The following is a description of a gene set: We identified Pparg as a major orchestrator of the phenotype of adipose-tissue resident regulatory T cells (VAT Tregs). To explore the contribution of Pparg1 and 2 in the generation of the VAT Tregs-specific gene signatures, CD4+FoxP3- T cells were transduced with Foxp3+/- Pparg1 (or Pparg2), treated with Pioglitazone or vehicle, and double sorted for microarray analysis. Genes down-regulated in CD4 over-expressing: FOXP3 and PPARg1 form of PPARG versus FOXP3. Human Gene Set: GSE37533_PPARG1_FOXP3_VS_FOXP3_TRANSDUCED_CD4_TCELL_DN from publication Cipolletta D, Feuerer M, Li A, Kamei N, Lee J, Shoelson SE, Benoist C, Mathis D (PMID 22722857) species: Homo sapiens, and this is the list of marker genes: PSMB10, PHF11 (PHD finger protein 11), GTPBP1, MCUB, IFI27, IRF2, LGALS8, STAT1, PRKD2, ZCCHC2, MSX1, IFIT2, BAZ2A, DNPEP, OAS2, HIVEP1, EIF2AK2, SLC15A3, LAP3, OASL, ZNF467, ZFYVE26, GMPR, FBXL7, VEZF1, CSF1, ANKFY1, CXCL10, MALT1, CXCL11, OGFR, NBN, WASHC4, TNFSF18, UBA7, LGALS9, GTF2B, TDRD7, TMBIM1, CASP7, PSME1, GOLM1, ELF1, TMEM62 (transmembrane protein 62), MX2, SHFL, STAT2, YEATS2 (YEATS domain containing 2), RABAC1, HERC5, LRRC32, RIPK1, IFI44, IFI35, CASP10, MX1, IL15, ZFPM2, DNAJA1, USP18, UBE2L6, SIDT2, HLA-A, SQOR, SLFN12, IRF9, IFIH1, WARS1, MEF2C, BST2, DYNLT1 (dynein light chain Tctex-type 1), LGMN, BAZ1A, SLC25A28, SIAH2, IRF1, APOL3, ETV7, ORC4, RNF138, ADAR, APOBEC3G, SECTM1, SPATS2L, PCNX1, RBM7, CYLD, TAP1, TRIM26 (NCBI Gene Id 7726), IRF7, USP25, LY6E, SOCS1, CD47, XAF1, TLR3, PLEKHA4, PML, TENT5A, RTP4, NAPA, TRAFD1, APOL6, MYCBP2, HLA-C, OPTN, VRK2, MAX, IFI16, IL15RA, TRIM38, CMTR1, GCNT1, ISG15, JAK2, PSMB8, NFYB, GCH1, BAG1, BTN3A3, THEMIS2, IFI6, CNP, TRIM22, IFI44L, HERC6, IFI30, JADE2, VEGFC, PSME2, IFIT1, NMI, CASP1, IFIT5, HLA-G, OAS1, ARID5A, TLE4, DDX60, SPTLC2, CALCOCO2, CBR3, DEDD, BTN3A1, N4BP1, RHBDF2, BAK1, FHL3, RIPK2, HLA-F, USP15, PARP4, HLA-J, TREX1, OAS3 (NCBI Gene Id 4940), SAMHD1, SP100, HLA-B, GBP1, RBCK1, HLA-E, TRIM14, EHD4, APOL1, IFIT3, SAMD9, IDO1, CTNNBL1, PLA1A, TAP2, RNF19B, MYD88, RNF114, RPS6KC1 (NCBI Gene Id 26750), KCTD14, RNF31, PSMB9, IFITM1, DHX58, GSDMD, PLSCR1, SP110, PARP12, SP140L, RSAD2, RAB9A (RAB9A, member RAS oncogene family), TRIM21, ISG20, PLAAT4, TNFSF10, TRANK1, ZC3HAV1, BCL2L13, NDUFA9, TMEM140, RIGI, APOL2, PPA1, IFITM2, GBP2